Given this list of marker genes LIN28B, TMEM176B, VANGL2, GLRX, ALKBH2, SLC27A3, APBB1IP, HMGB1, NCLN, CD226, NFE2L2 (NFE2 like bZIP transcription factor 2), MYT1L, CD9, PRICKLE1, SCPEP1, FBXL20, MYO7B, CLDN1 (NCBI Gene Id 9076), RFK, PDE11A, TMEM171, CLEC9A, KLK12, DENND6A, TRIM15, ACOX2 (acyl-CoA oxidase 2), KCNA2, CYYR1, NEURL1B, IL24, FNDC5 (fibronectin type III domain containing 5), WDPCP, SIGIRR, LAIR1, LY6G5B, PTPN3 (protein tyrosine phosphatase non-receptor type 3), CD300C, IFT74, TRPM4, SMAD4, LARGE1, CCDC88A, PTGS1, POC1B, ANAPC10, FLT3, MMP9, ACAP1, OSBPL7, MYO10, C2, CTNND2, TET1, SCGB1A1, STON2, IL13RA1, RNF144B, VPS26C, GOLPH3L, AKAP7 (A-kinase anchoring protein 7), POLR3A, TYROBP, ADGRE4P, RSU1 (NCBI Gene Id 6251), RFX2, THEMIS2, AGXT, GP2, NRIP1, SCNN1G, CDK3, KLF3, KRT39, ENO3, CLEC1B, FBXW10, IGSF6, KCNJ16, UBL7, MBLAC2, LIFR, LY96, INPP5K, TMEM184C, CCDC184, TAGLN2, HPGD, GRIK1, IL17RB, ECT2L, LRRC23, NUFIP2, PIAS3, FHIP2B, TNFSF9, NKX2-6, BHLHA15, SCNN1A, SLFN5 (NCBI Gene Id 162394), DMWD, ABCA2 (NCBI Gene Id 23153), PAXX, SLCO1C1, DPM2, ACOX3, IFI30, IDH3G, WDR35, SIRPA, CUEDC1, PLA2G7, PPT1, CGA, ITGA9, NXPE3, RNASEL, CFI, TRAPPC2L, TADA3, ACTR6, NAV1, GSTT2, CD48, CIZ1 (NCBI Gene Id 25792, CDKN1A interacting zinc finger protein 1), INTU, GHDC, CCDC69, RASA3, XAF1 (NCBI Gene Id 54739), SCNM1, LRRC56, NR2C1, FANCL, here is a description of the gene set: from publication Sundrud MS, Koralov SB, Feuerer M, Calado DP, Kozhaya AE, Rhule-Smith A, Lefebvre RE, Unutmaz D, Mazitschek R, Waldner H, Whitman M, Keller T, Rao A (PMID 19498172) T cell differentiation to the Th17 effector subset requires stimulation through the T cell and co-stimulatory receptors, together with cytokine stimulation by TGFb and IL-6. The small molecule halofuginone (HF) inhibits Th17 cell development and induces a pattern of stress-regulated gene expression that mimics amino acid starvation. We used global transcript profiling to ask how halofuginone modulates gene expression induced during T cell activaiton and Th17 differentiation Human Gene Set: GSE15624_CTRL_VS_6H_HALOFUGINONE_TREATED_CD4_TCELL_UP studied in species Homo sapiens Genes up-regulated in CD4 T cells: control versus treated with halofuginone for 6h.